The following is a description of a gene set: Human Gene Set: LEE_DIFFERENTIATING_T_LYMPHOCYTE To develop a comprehensive catalogue of phenotypic and functional parameters of human CD4(+) T cell differentiation stages, we have performed microarray gene expression profiling on subpopulations of human thymocytes and circulating naive CD4(+) T cells, including CD3(-)CD4(+)CD8(-) intrathymic T progenitor cells, CD3(int)CD4(+)CD8(+) 'double positive' thymocytes, CD3(high)CD4(+)CD8(-) 'single positive' thymocytes, CD3(+)CD4(+)CD8(-) CD45RA(+)CD62L(+) naive T cells from cord blood and CD3(+)CD4(+)CD8(-) CD45RA(+)CD62L(+) naive T cells from adult blood. These subpopulations were sort-purified to >98% purity and their expressed RNAs were analyzed on Affymetrix Human Genome U133 arrays. Comparison of gene expression signals between these subpopulations and with early passage fetal thymic stromal cultures identify: (i) transcripts that are preferentially expressed in human CD4(+) T cell subpopulations and not in thymic stromal cells; (ii) major shifts in gene expression as progenitor T cells mature into progeny; (iii) preferential expression of transcripts at the progenitor cell stage with plausible relevance to the regulation of expansion and differentiation of these cells; and (iv) preferential expression of potential markers of recent thymic emigrants in naive-phenotype CD4(+) T cells from cord blood. Further evaluation of these findings may lead to a better definition of human thymopoiesis as well as to improved approaches to monitor and to augment the function of this important organ of T cell production. species: Homo sapiens from publication Lee MS, Hanspers K, Barker CS, Korn AP, McCune JM (PMID 15210650) Genes enriched at every T lymphocyte differentiation stage compared to the early passage fetal thymic stromal cultures (TSC)., and this is the list of marker genes: TCF7, P2RY8, ARHGDIB, TRBC1, AIF1, SORL1, ARHGAP25 (NCBI Gene Id 9938), LNPEP, ITM2A, SFPQ, FUBP1, GMFG, PVRIG, ATP8A1, INPP4A (inositol polyphosphate-4-phosphatase type I A), ATP8B1, PSMB9, ZNF160, DOCK2, SEC31B, SATB1, RCSD1, CD247, APBB1IP, STX16, EIF4A1, CBX4, NUP210, KLHL6, ITK (NCBI Gene Id 3702), C2orf68, ICAM2, GTF3A, BTG2, MPHOSPH9, ING3 (inhibitor of growth family member 3), MDM4, ITGAL, TSPOAP1-AS1, ARHGAP9, PSMA3-AS1, RASGRP1 (NCBI Gene Id 10125), TSTD1, ZNF586, ARHGAP30, CD3G, BRD2, NFATC2IP, NCKAP1L, LEF1-AS1, CAMK1D, RNASET2, TRG-AS1, HCLS1, GATA3, SLFN5, MAL (mal, T cell differentiation protein), CXCR4, UCP2, PCGF3-AS1 (NCBI Gene Id 107986211), AKAP13, TRBC2 (NCBI Gene Id 28638), TMC6, PTPRC, LPXN, PDE7A, PRKCB, SNX20, FNBP1, ALDH5A1, TMEM71, ZNF207, SELPLG, TMC8, UBE2G2, UBASH3A (ubiquitin associated and SH3 domain containing A), LAPTM5, EVI2A, RYBP, TRIM14, SLC46A3, NHERF1, CCDC152, SP110, MR1, SH2D1A, GUSBP14, METAP2, SRRM2, KDM5A, CD48, BTG1, OCIAD1, EPB41, ZNF148, NDUFS8, ZNF266, AKNA, DCLRE1C, TMEM131L, LAT, CDK13, CUTALP, IKZF1, MIR142, FKBP5, GALK2, SASH3, TBC1D10C, IL7R, ATF7IP2, NPIPB3, FLI1, PRKCH, USF3, EVL, FYB1, CEP350, CD53, DGKA, CELF2, PIK3CG, RHOH, IPCEF1, RASSF5, MTF2, CD52, CCND3, HAUS2, LINC01215, AHSA2P, SLA, ZNF397, PRKCQ, AP1G2, MGAT4A, ALMS1, ARHGAP15 (Rho GTPase activating protein 15), TRAPPC6A, AQP3, LTB, CYTH1, SRSF6 (NCBI Gene Id 6431), DICER1, NLRC3, BCL11B, MAP4K1, GPR174, SEPTIN6, TRGC1, PAG1, SELL, PNISR, CORO1A, LEF1, EVI2B, QNG1, TNFAIP8, ZC3H7B, TAGAP, LAX1, TRAT1, HDAC4, ZFP36L2, ARHGAP45, RAC2, CNOT6L, CRACR2A (calcium release activated channel regulator 2A), BCL2L11, ITGB2-AS1, ITGB2, RBM33, VAV1, RGCC, ICOS, TXNIP, SEMA4D, CYFIP2, KMT2E, VAMP1, KLF13, SP1, IFNAR2, SPATA13, LCK, TMBIM4, GABPB1-AS1, DOCK8, CD3D, GIMAP2, ARHGEF6, SMDT1, FGFR1, PGGHG, CD2, TRAF3IP3, CD96, MYCBP2, SRSF7, FAM107B, ADA2, TRIM56